Given this list of marker genes NCF1, CEBPE, PIM1 (NCBI Gene Id 82453), MERTK, PLEK, SMOX, NDRG1, THBD, FGR, ALOX5AP, SLA, SLC2A5, here is a description of the gene set: Acute promyelocytic leukemia (APL) is associated with chromosomal translocations involving retinoic acid receptor alpha (RAR alpha) and its fusion partners including promyelocytic leukemia (PML) and promyelocytic leukemia zinc finger (PLZF). Using oligonucleotide arrays, we examined changes in global gene expression mediated by the ectopic expression of either PML/RAR alpha (retinoid-sensitive) or PLZF/RAR alpha (retinoid-resistant) in U937 cells. Of more than genes analyzed, genes were commonly up-regulated, and genes were down-regulated by both fusion proteins suggesting their role in the APL phenotype. In our APL model, for example, TNFAIP2, TNFR2, ELF4, RAR gamma, and HoxA1 were down-regulated by both fusion proteins in the absence of retinoic acid (RA). RA strongly up-regulated these genes in PML/RAR alpha, but not in PLZF/RAR alpha expressing U937 cells. Expression studies in NB4, retinoid-resistant NB4-R2, normal human CD34+ cells, and APL patient samples strongly suggest their role in the regulation of granulocytic differentiation. Furthermore, combined treatment with tumor necrosis factor alpha (TNF alpha) and RA synergistically enhanced granulocytic differentiation in NB4 cells but not in NB4-R2 cells. Our data indicate that APL pathogenesis and retinoid-induced granulocytic differentiation of APL cells involve genes in the cell death pathway, and that cooperation between the RA and TNFalpha signaling pathways exists. Targeting both the retinoid-dependent differentiation and the cell death pathways may improve leukemic therapy, especially in retinoid-resistant acute myeloid leukemia. species: Homo sapiens from publication Park DJ, Vuong PT, de Vos S, Douer D, Koeffler HP (PMID 12893766) Human Gene Set: PARK_TRETINOIN_RESPONSE Genes up-regulated in U937 cells (acute promyelocytic leukemia, APL) by tretinoin (ATRA).